Given this list of marker genes H2AB1, H2BC1, H2AZ2, H3C15, H2BC13, RAD51, PRDM9, H2BC12, RPA3 (replication protein A3), H2AC20, H2AC4, H4C1, MRE11, FIGNL1, H2BC11, H2BC9, H3-3A, RPA1, H2BC3, H2BC14, H2BC15, RPA2, H2BC26, H2AJ, RAD51C, H2BC17, PSMC3IP, MSH5, MSH4, ATM, BRCA2, H2AX, MLH1 (mutL homolog 1), H2AC6, H3-4, H2AC7, H2BC21, DMC1, MND1, TOP3A, H2BC4, CDK4 (NCBI Gene Id 92978), H2AC18, TEX15, BLM, H2AC14, CDK2, H2BC12L (NCBI Gene Id 54145), SPO11, BRCA1, H3C1, RBBP8, H2BC5, MLH3, NBN, FIRRM, RAD50, here is a description of the gene set: part of: Meiosis Meiotic recombination exchanges segments of duplex DNA between chromosomal homologs, generating genetic diversity. There are two forms of recombination: non-crossover (NCO) and crossover (CO). In mammals, the former is required for correct pairing and synapsis of homologous chromosomes, while CO intermediates called chiasmata are required for correct segregation of bivalents.<br>Meiotic recombination is initiated by double-strand breaks created by SPO11, which remains covalently attached to the 5' ends after cleavage. SPO11 is removed by cleavage of single DNA strands adjacent to the covalent linkage. The resulting 5' ends are further resected to produce protruding 3' ends. The single-stranded 3' ends are bound by RAD51 and DMC1, homologs of RecA that catalyze a search for homology between the bound single strand and duplex DNA of the chromosomal homolog. RAD51 and DMC1 then catalyze the invasion of the single strand into the homologous duplex and the formation of a D-loop heteroduplex. Approximately 90% of heteroduplexes are resolved without crossovers (NCO), probably by synthesis-dependent strand annealing.<br>The invasive strand is extended along the homolog and ligated back to its original duplex, creating a double Holliday junction. The mismatch repair proteins MSH4, MSH5 participate in this process, possibly by stabilizing the duplexes. The mismatch repair proteins MLH1 and MLH3 are then recruited to the double Holliday structure and an unidentified resolvase (Mus81? Gen1?) cleaves the junctions to yield a crossover. <br>Crossovers are not randomly distributed: The histone methyltransferase PRDM9 recruits the recombination machinery to genetically determined hotspots in the genome and each incipient crossover somehow inhibits formation of crossovers nearby, a phenomenon called crossover interference. Each chromosome bivalent, including the X-Y body in males, has at least one crossover and this is required for meiosis to proceed correctly.<br><br>For review, please refer to Cohen et al. 2006, Inagaki et al. 2010, Handel and Schimenti 2010.<br><br>The FIRRM:FIGNL1 complex has recently been reported to interact with both RAD51 and DMC1 recombinases and limit the formation of meiotic crossovers by regulating RAD51 and DMC1 dynamics during meiosis. species: Homo sapiens Reactome Pathway: Meiotic recombination